The following is a description of a gene set: This event has been computationally inferred from an event that has been demonstrated in another species.<p>The inference is based on the homology mapping from PANTHER. Briefly, reactions for which all involved PhysicalEntities (in input, output and catalyst) have a mapped orthologue/paralogue (for complexes at least 75% of components must have a mapping) are inferred to the other species. species: Mus musculus part of: Translation electronically inferred by orthology from the curated human pathway Reactome Pathway: tRNA Aminoacylation, and this is the list of marker genes: Ppa1, Ppa2